The following is a description of a gene set: Fusion of a middle phalanx of a finger with another bone. Human Gene Set: HP_SYMPHALANGISM_OF_MIDDLE_PHALANX_OF_FINGER Symphalangism of middle phalanx of finger studied in species Homo sapiens, and this is the list of marker genes: NONO, NOG, UBAP2L (NCBI Gene Id 9898), ROR2, GDF5, PQBP1, SF3B4, TFAP2B, BHLHA9